Given this list of marker genes Trmt2b, Syncrip, Fdxacb1, Elp4, Trmt1, Dus3l, Dph3, Dtwd1, Elp3, Trmt10c, Pusl1, Trmt6, Rpusd4, Pus7l, Larp7-ps, Rpusd1, Cdkal1, Trmt10a, Sars1, Rbm15, Thg1l, Tsr3, Trdmt1, Tprkb, Elp5, Dus4l (NCBI Gene Id 78387), Lcmt2, Kti12, Mrm2, Qng1, Pus7, Gon7, Mettl4, Mtfmt, Nop10, Trmt61a, Ctu1, Emg1, Dnajb11, Rpusd2, Thumpd1, Tyw5, Tarbp1, Dtwd2 (NCBI Gene Id 68857), Thumpd2, Nsun5, Pus1, Aars1, Nhp2 (NHP2 ribonucleoprotein), Mettl6, Dus1l, Alkbh8, Tyw3, Rbm47, Ctu2, Bag4, Nop2, Thumpd3, Trmt1l, Nsun6, Mettl16, Gtdc1, Trub1, Elp1, Nsun2, Tfb2m, Qtrt2, Fbl, Ftsj3 (FtsJ RNA 2'-O-methyltransferase 3), Adad1 (NCBI Gene Id 21744), Apobec3, Fbll1, Tyw1, Trmu, Trub2, Rpusd3 (NCBI Gene Id 232330), Wtap, Dkc1, Trmt112, Wdr6, Rnmt, Trmt44, Mettl14, Elp2, Ftsj1, Mrm3, Mrm1, Bcdin3d, Sepsecs, Nsun3, Adarb2, Adat2, Mettl1, Hnrnpab, Tgs1, Trmt13, Jmjd6, Apobec2, Mettl15, Cdk5rap1, Adad2, Tfb1m, Trmt5, Dimt1, Nat10, Nsun4, Larp7, Ramac, Elp6, Trit1, Hsd17b10, Trmt10b, Trmt9b, Dalrd3, Thada, Dus2, Mocs3, Apobec1, Mto1, Bud23, Mettl8, Gtpbp3, Mettl5, Mettl2, Pus10, Alkbh1, Gar1, Qtrt1, Henmt1, Osgep, Trmt12, Ankrd16, Naf1, Pus3, Adarb1, A1cf, Urm1, Hnrnpc, Aicda, Adar, Osgepl1, Wdr4, Yrdc, Rbm15b, Mepce, B3gntl1, Mettl3, Akt1, Trmo, Zcchc4, here is a description of the gene set: Mouse Gene Set: GOBP_RNA_MODIFICATION studied in species Mus musculus The covalent alteration of one or more nucleotides within an RNA molecule to produce an RNA molecule with a sequence that differs from that coded genetically.